The following is a description of a gene set: Human Gene Set: HP_CHROMOSOMAL_BREAKAGE_INDUCED_BY_IONIZING_RADIATION Chromosomal breakage induced by ionizing radiation Increased amount of chromosomal breaks in cultured blood lymphocytes or other cells induced by treatment with ionizing radiation. species: Homo sapiens, and this is the list of marker genes: SMO, RNF168, BAP1, SUFU, PDGFB (NCBI Gene Id 5155), SMARCB1, RAD50, TRAF7, PIK3CA (NCBI Gene Id 5290), TERT, AKT1, SMARCE1, NF2